The following is a description of a gene set: Human Gene Set: REACTOME_G2_M_DNA_DAMAGE_CHECKPOINT G2/M DNA damage checkpoint species: Homo sapiens, and this is the list of marker genes: RHNO1, YWHAQ, NBN (NCBI Gene Id 4683), YWHAE, H4C2, MDC1, H4C15, PIAS4, H2AX (NCBI Gene Id 3014), H2BC12L, RPA2, H2BC1, HUS1, EXO1 (NCBI Gene Id 9156), CHEK2, WRN (WRN RecQ like helicase), RFC4, CCNB1 (cyclin B1), MRE11, RBBP8, H2BC15, UBE2N, TP53, DNA2, H2BC10, RAD9A, HERC2, H4C11, H4C8, ATM, H4C5, H2BC4, H2BC6, H3-4, H4C3, CDK1 (NCBI Gene Id 983), RNF8, ATR, H4C1 (NCBI Gene Id 8359), UBE2V2, YWHAB, H2BC13, BRCC3, ABRAXAS1, KAT5, H2BC12, WEE1, RFC2, CHEK1, CDC25C, TP53BP1, YWHAG, H2BC14, YWHAZ, RFC3, H2BC3, H2BC21, H4C13, BABAM1, H2BC17, RNF168, CCNA2, H4C6, RMI1, YWHAH, H4C9, H4C14, H2BC8, SFN, H4C16, BABAM2, H4C4, RPA3, H2BC9, H2BC7, RFC5, ATRIP, RAD50, RPA1, BRIP1, NSD2, H4C12, H2BC11, UIMC1, H2BC5, TOPBP1, RMI2, BLM, RAD1, BARD1, TOP3A, H2BC26, CCNA1, RAD17, RAD9B, BRCA1